The following is a description of a gene set: Human Gene Set: HP_ABNORMAL_UPPER_LIP_MORPHOLOGY studied in species Homo sapiens Abnormal upper lip morphology An abnormality of the upper lip., and this is the list of marker genes: STX1A, TMEM94, KRAS, AP1G1, FKTN, RPS19, SLC35A2, DHX30, HOXD13, TRMT10A, MYH8, CLCN3 (NCBI Gene Id 133073), SEC24C, WBP4, LIMK1, IDH1, EMC1, INTU, FBN1, LRRC32, OTUD7A, CNOT1, WDR19, ANTXR1, AFF2, ATP1A2 (ATPase Na+/K+ transporting subunit alpha 2), AFF4, TFAP2B, BRAF, LARP7, POR, MOCS2, RAP1B, EZH2, IFT81, MEOX1, ERLIN2, BMP4, MFSD2A, WLS, COG1 (NCBI Gene Id 9382), MRPS28, PURA, PIEZO2, DVL3, RAD21, PPP3CA, TRIO, EDAR, BUB1, TMEM237, TET3, SCN4A, PDHA1, ARNT2, EPB41L1, MYMK, AMPD2 (adenosine monophosphate deaminase 2), NAA80, PACS1, TNRC6B, DPM1, CCN2, VPS13B, ALG9 (ALG9 alpha-1,2-mannosyltransferase), MINPP1, CHST14, RIPK4, AGO1 (NCBI Gene Id 26523), ITCH, NELFA, PIGN, SPTBN1, SATB1, SMARCE1, NOVA2, RAC3, DNAJC30, VPS51, TBCE, PUS7, DPF2, CDH1, TOR1A, KCNK9, CHRNG, COL3A1 (collagen type III alpha 1 chain), CLCN6, SC5D, GREB1L, MKS1, COLEC11, GJA1, ARMC9, TMEM147, CAPRIN1, TGDS, IFIH1, PIGG, RTL1, RAB3GAP2, MSL3, LMNB1, TTC8, GPC3, DHCR7, YARS2, DPYD, SSR4, RFX7, NLRP1, UNC80, MGP, SOX9, PUS1, ZNF699 (zinc finger protein 699), GP1BB, AP4M1, OSTM1, WARS2, ANKLE2, OPHN1, CBL, MCM7, TLK2, MBD5, BAP1, PSMD12, TFAP2A, MEIS2, NEK9, NALCN, BBS1, ATG7, DOCK7, IL1RAPL1, FGF3, KAT6A, FOXH1, TMEM270, AMER1, ATP6V1E1, TBL1XR1, CEP63, DDX59, OTUD6B (OTU deubiquitinase 6B), GNB1, AHDC1, BCAS3, VAX1, TBC1D20, GMPPA, TCF3, EIF2S3, DBR1, PTPRF, AVP, CDK5RAP2, CASP2, CSGALNACT1, TUBGCP2 (tubulin gamma complex component 2), ATP7A (ATPase copper transporting alpha, NCBI Gene Id 613259), SUMO1, PPP1R15B, HIVEP2, PARS2, KMT2D, SCAPER, BAZ1B, LUZP1, CEP290, MASP1, DDX6, ZFX (NCBI Gene Id 7543), EXOC2, PTRH2, TUBB, MAF, ABCC8, CAMK2G, GATAD2B, SPRED2, PIGQ, EXT2, BBS5, ASXL2, ATP9A (ATPase phospholipid transporting 9A (putative)), KANSL1, SCLT1, ATN1, MUSK, UBE4B, H3-3A, KATNB1, WNT3, PGAP2, KCNJ8, CHAMP1, ZPR1, LZTFL1, H4C5, NBAS, PAM16, USB1, COLEC10, ADAMTSL2, CCDC22, TP63, MESD, PRMT7, NUAK2, BRCC3, ITGA8, ADAMTSL1, ZSWIM6, TBC1D24, ZC4H2 (zinc finger C4H2-type containing), ZDHHC9, PIGW, ACTA1, FLII, OFD1, RIN2, TAOK1, KDM1A, NSUN2, BBS7 (NCBI Gene Id 55212), PHIP, NCF1, SASS6, ARX, AFG2B, NSD2, UFD1, BRAT1, PBX1, KDM5B, PACS2, ADNP, YWHAE, PQBP1, PCLO, PIGA, OCA2, AP4B1, TPR, MLXIPL, MEF2C, MARS2, GAS1, EDARADD, CASK, METTL23, PREPL, FKRP (fukutin related protein), WDR35, RNU4-2, FGD1, MED12L, PTH1R, TBCK, CILK1, TRAPPC14, SMOC1, HERC2, PIGK, MAB21L2, ERMARD, WWOX, SPECC1L, NXN, DLX4, ADGRG6, PIGL (phosphatidylinositol glycan anchor biosynthesis class L), MYOD1, PPP2R3C, TMEM70, SNIP1, NCAPG2, TBX4, IRF6, SNORD115-1, TRIM32, ROBO1, RAI1, NSDHL, MAB21L1, TAF8, TAF13, ROR2, BBS10, PRKCZ, CNOT3, NAA20, ZNF148, MAP1B, KIF14, MED12, BCOR, FREM2, RNF135, UBAP2L, H4C9, FLNB, RREB1, PRKAR1B, ZNF462, SCN1A, TMEM53, RECQL4, THSD1, EXOC7 (exocyst complex component 7), GNPTAB, ANKRD17, EBP, DDB1, SETD5, B3GLCT, WDR62 (WD repeat domain 62), KNL1, MOCS1, CHD5, NPHP1, MID2, MED27, FAT4, NSD1, POLR3GL, BUD23, EP300, SMARCD1, ATP6V0A2, COL11A1, EVC2, KCNJ11, PIGV, FGFR2, IFT74, ALDH6A1, PYCR2, TMLHE, SNORD116-1, CPLX1, QRICH1, CHMP1A, CLIP2, MED13, GRIP1, MAN1B1, KCNK4, BRPF1, HS2ST1, PGAP3, CDK10, COX7B, BPTF, POLR1C, FREM1, PSMC3, ALG13, EFNB1, TTI1, FBXL4, SIN3A, SMARCA4, GJA5, ANKRD11, RAB11B, YAP1, KCNJ2, PHF8, FBXO28, KDM5C, PIK3CA, SNRPB, ASCC3, RUNX2, PRIM1, CHST3, MSX2, SMARCB1 (NCBI Gene Id 6598), SLC45A1, KDM3B, ANO1, SRCAP, MPC1, KARS1, CSNK2B, PRKDC, BBS12, PDGFRB, YY1, TPM3, TRRAP, PIGS, TWIST1, POGZ, PTCH1, PIGY, BMP2, JUP, DSE, PRKACA, MCTP2, AP4E1, POLR3A, CTBP1, CHD7, HES7, BCKDK, ACTB, NEK1, POC1A (POC1 centriolar protein A), MTX2, CUL7, FGF20, PPP2R5D, PAFAH1B1, MKKS, WDPCP, FGF8, KIAA0753, NUP107, RPS7, RAB18, CHSY1, KCNH1, STT3A, DNMT3A, NEXMIF, SLC9A7, CDC42BPB, KDF1, DDX3X, PHF21A, DHX37, LTBP4, KIF11, PLPBP, BUB1B, DYNC2LI1, CTCF, GPC6, RALA, SMS, ZEB2, TAF6, ARVCF, ATRX, CNTNAP2, PGM2L1, NRAS, FKBP6, CCNK, NAA10, UPF3B (NCBI Gene Id 65109), ADSL, GABBR1, ASH1L, MAPK8IP3, PHGDH, IARS2, AGO2, DLK1, TRPM3, IFT80, FIG4, SNRPN, WNT9B, TRIP11, KLHL41, POMT1, STAG2, TCTN3, EIF5A, SETBP1, NFIB, UGP2, EBF3, OBSL1 (NCBI Gene Id 731094), SHH, ATIC, RIC1, SF3B4, ARID2, ESCO2, ZNF407, WDR37, MADD, AARS1, C12orf57, ACBD6, FOXC2, MYL2, NRCAM, EPG5, NDN, CHUK, MAP2K1, RSPO2, ZNHIT3, BRCA1, NPAP1, INPPL1, METTL5, PYCR1, DDR2, DMPK, FBXO11, NOG, BCR (BCR activator of RhoGEF and GTPase), SMPD4, TCF4, PLCH1, CFAP418, PCDHGC4, DYM, AASS, RAB3GAP1, RTTN, WAC, ALG11, GLI2, DENND5A, DHPS, CHD2, GRIA3, NIPBL (NIPBL cohesin loading factor), ALG12, FLI1, SLC25A46, CCNQ, MAGEL2, KIF15, EDEM3, OGT, AMMECR1, SOX4, EXOSC1, WDR4, WNT4, SATB2, BBS4, SMC3, ELN, KIDINS220, DLL1, EIF4A2, MYCN, PIGO, RFC2, SIX3, GTF2IRD2, CRKL, ARSK, FRAS1, POLR1A, VPS37D, COG7 (NCBI Gene Id 91949), RYR1, TMCO1, NKAP, KDM6A, RIPPLY2, CLP1, CAMTA1, MMP23B, H3-3B, CDH11, TAF4, CTNNB1, FGFR1, NECTIN1, ZBTB18, HNRNPC, SKIC3, EIF4H, AGL, NOTCH2, ZNF526 (zinc finger protein 526), WASHC4, SUMF1, ALX3, KCNJ6, NR4A2, TALDO1 (NCBI Gene Id 6888), MMACHC (NCBI Gene Id 25974), CD96, KMT2A, DPYSL5, RERE, LAS1L, PKDCC, KCNAB2, TAF1, SHANK3, BRD4, PLAA (NCBI Gene Id 9373), PTEN, KCNJ5, GNB2, MAP3K7, BBS2, RPL10, CDK19, GOLGA2, SLC6A17, EDA2R (NCBI Gene Id 60401), CDON, IGF1R, GNE, BCL11A, PRKACB, CDKL5, CRIPTO, KDM5A, DHODH, CEP135, STXBP1, FOXG1, PIGU, FLNA, ARHGAP31, KAT5, CREBBP, ERCC1, CASZ1, ERF, IER3IP1 (immediate early response 3 interacting protein 1), CUL4B, CC2D2A, NSRP1, PAH (NCBI Gene Id 5053), RHOBTB2, CNOT2, PDPN, BBS9, GLB1, MAPK1, CDC42, HDAC6, U2AF2, PDCD6IP, RECQL, GPC4, SCAF4, NONO, B3GAT3, CCDC8, PDE4D, HIC1, GDF11, B3GALT6, IRX5, HNRNPH2, AP3D1, PPP1R21, LFNG, PAK3, EXOSC2, SLC35A1, RPL5, SKI, ABL1, OCLN, SLC35C1, DEAF1 (NCBI Gene Id 105376508), VAC14, KCNMA1, HSPG2, NEB, ZNF292, CPLANE1, HRAS, SLC29A3, TRAPPC9, CACNA2D1, SMARCC2, PHC1, UBE3B, AP2M1, IFT43, POMT2, TCF20, H4C11, SPEN, MSX1, IL6ST, CANT1 (calcium activated nucleotidase 1), SMARCA2, LARGE1, VPS35L, EXT1, PCGF2, SLF2, ARID1A, MYH3, AP1S2, EDA, SDCCAG8, ASPM, AP3B1, NFIX, IFT172, ALG8, CRLF1, GALNT2, HNRNPU, PITX2, PROKR2, CACNA1A, HUWE1, POLR1D, SNAI2, CACNA1C, RSPRY1, SEMA3E, IFT140, LEMD2, SH3PXD2B, SRRM2, ORC4, GTF2IRD1, CLTC, EHMT1, HSD17B4, SLC6A1, MAP2K2, ZMIZ1, CEP120 (centrosomal protein 120), SON, EXTL3 (NCBI Gene Id 2137), LRP4, COL2A1, TASP1, GABRD, CEP295, POU4F1, SIM1, SNX14, LETM1, AGR2, FZD2, CSF1R, ASXL3, CLIC2, COG8, SHOC2, PIGB, TRAPPC10, DHX9, ZIC2, TBX5, NFIA, ESAM, LTBP3, COMT, DPM2, THOC6, MKRN3, MEGF8, TGFB3, SMO, MICU1, BMP1, MCPH1, CDC6, HK1, B4GALT1, HYLS1, FAR1, GRIA4, ABCC9, GBA1, KIF7 (kinesin family member 7), NARS2, PPP2R1A, DIS3L2, CENPE, PWRN1, COPB2, SUPT16H, GFRA1, ARID1B, CAMSAP1, PUF60, RNU4ATAC, AP4S1, H4C3, NCAPD3, JARID2, TAPT1, ATP1A3, EEF1A2, TRIP12, MYMX, MYT1L, CLCF1, TCTN2, HPDL, CDK6, PPM1D, PRDX1, USP9X, LMBRD1, KIT, XYLT2, KIF26A, AFF3, SARS1, BCL11B, DYNC2I2, EVC, PPP1R12A, SMC1A, WARS1, TBX1, SUZ12, BRF1, PPP1CB, GJA8, RET, DYRK1A, MYO18B, CERT1, MEG3, TRAPPC4, HDAC8, FGFRL1, POLR1B, TBR1 (T-box brain transcription factor 1), CUX1, MESP2, INTS11, KDM4B, UBR1, SPIN4, CDK13, UFC1, CEP19, FOXP2, CDH2, CKAP2L, DLL3, GRHL3, WNT5A, HMBS, FILIP1, TENM3, ERCC6, PIGT, CCBE1, STIL, ACTG1, ATP6V1A, HOXB1, RPGRIP1L, NODAL, THUMPD1, C1GALT1C1, RAB5IF, DISP1, MGAT2, COL11A2, SLC25A24, TTC5, LMX1B, FLCN, GLI3 (NCBI Gene Id 2737), SPOP, ODC1, TRIM8, LTBP1, APC, TXNL4A, SHMT2, COG3 (NCBI Gene Id 83548), CHD8, AUTS2 (activator of transcription and developmental regulator AUTS2), TWIST2, CSNK2A1, SLC2A1, PAX3, MED25, NBN (nibrin), NUP37 (NCBI Gene Id 79023), ASXL1, ADAMTS3, PWAR1, GAD1, CRELD1, PMM2, TCOF1, SYT1, OCRL, SETD1A, SMAD4, SYNGAP1, MECP2, SEC23A, KAT6B, DYNC2H1, GLIS3, XYLT1, TNPO2, JMJD1C, ACER3 (NCBI Gene Id 55331), PEX26, FOXL2 (forkhead box L2), DCHS1, NOTCH3, ARHGEF2, CEP152, DCPS (NCBI Gene Id 28960), RNF2, CRTAP, TOE1, CYFIP2, SMG8, BBIP1, IQSEC2, STIM1, UBR7, TNNI2, TGIF1, SUFU, STRADA, CIT, HIRA, HECTD4 (HECT domain E3 ubiquitin protein ligase 4), ITPR1, IREB2, UBE2A, EFTUD2, CYP26C1, PPP2CA, PORCN, IFT57, RAP1GDS1, TBL2, MAPRE2, PRDM16, SLC1A3, GNAI1, SLC4A10, FRA10AC1, SF3B2, GTF2I, KIFBP, WDR26, SLC26A2, MTOR, DVL1, ADARB1, DYNC2I1, TSPAN7, IFT27, METTL27, RAPSN, ARL6, INTS1, NF1, LZTR1, SLC2A10, HNRNPK, UGDH, ALX4, TRPS1, SOX11, SYNE1, ATP6V1B2, EFEMP1 (EGF containing fibulin extracellular matrix protein 1), STEEP1, MID1